Given this list of marker genes Ntrk3, Nradd, Hap1, Sort1, Furin, Ntf3 (NCBI Gene Id 30909), Ntrk2, A2m, Pcsk6, Pzp, Ntrk1, Fstl4, Ngfr, here is a description of the gene set: Binding to a neurotrophin, any of a family of growth factors that prevent apoptosis in neurons and promote nerve growth. species: Mus musculus Mouse Gene Set: GOMF_NEUROTROPHIN_BINDING